Given this list of marker genes Srsf4, Srsf7, Ptbp3, Sfswap, Hnrnpk, C1qbp, Rbm20, Hnrnpa2b1, Rbm10 (RNA binding motif protein 10), Acin1, Dyrk1a, Srsf10, Akr1c6, Sap18b, Pcbp4, Sap18, Celf4, Rbmxl1, Npm1, Srsf9, Srsf6, Rbm42, U2af2 (NCBI Gene Id 22185), Ptbp1, Rnps1, here is a description of the gene set: Any process that stops, prevents, or reduces the frequency, rate or extent of mRNA processing. studied in species Mus musculus Mouse Gene Set: GOBP_NEGATIVE_REGULATION_OF_MRNA_PROCESSING